Given this list of marker genes PLPP2, PLPP6, SGPP1, PLPP3, PLPP7, PLPP1, SGPP2, here is a description of the gene set: Human Gene Set: GOMF_SPHINGOSINE_1_PHOSPHATE_PHOSPHATASE_ACTIVITY Catalysis of the reaction: sphingosine 1-phosphate + H2O = sphingosine + phosphate. studied in species Homo sapiens